The following is a description of a gene set: Genes predicted to be targets of miRBase v22 microRNA hsa-miR-2110 in miRDB v6.0 with MirTarget v4 prediction scores > 80 (high confidence targets). from publication Chen Y, Wang X (PMID 31504780) studied in species Homo sapiens Human Gene Set: MIR2110, and this is the list of marker genes: RNF169, SMAGP, ARFGEF3, IL6ST, PCM1, TBC1D8B, SGTB, GPR135, PRDM8 (NCBI Gene Id 56978), WASF2, WNT5A, XBP1, GBP3, RSAD2, ELK1, CALCA, ZFX, MMACHC, PTGR3, MCPH1, YY1AP1, ASPH, ASTN1, CCL8, CXCL11, OLIG1, HECTD3, ZMAT4, ENO2, UBE3C, SERINC1, UBR3, ITSN1 (NCBI Gene Id 6453), WBP1L, HSPE1-MOB4, ATP6V1G2, ZNF609, HNRNPA1, PTOV1, BCAM, USP12, TBR1, TPH1, PTER, NRAS, GDF11, CEP135, ZFP28, AGAP2, PI4KB, SPOCK3, CNIH3, THAP2, ENAM, DIRAS2, RARB, CD1E, SLC25A33, MBD2, TNRC6A, PRCC, G3BP1, FGFR1, VWC2 (von Willebrand factor C domain containing 2), RPN2, RAB11FIP2, ACSL1, IFNLR1, MAP2K1, SLC41A1, PSTPIP2, ELAVL3, PTPN14, MOB4, BNC2, ETV4, MAP1A, MOCS1, YTHDC1, ZDHHC15, ZBTB4 (zinc finger and BTB domain containing 4), PYGB, ZNF831, LUC7L3, MED9, SUSD2, ZHX3, KIAA0825 (NCBI Gene Id 401202), KIF21B, ITPRID1, C1QTNF3, GGPS1, SEMA5A, RPH3A, CYYR1, CD69, NRIP1, COPZ2, PTPN1, CSNK1A1, LUZP2, PLEKHH1, TAOK3, NADK2, PSKH1, SMIM19, UNC5B, IGF2BP3, ZBTB39, CUL3, CCDC82, UVSSA, ZNF620, NECTIN2, SIPA1L3, TMED4, SH3BP4, S1PR3, YES1, CAPN11, TRAM1, MR1, FCHSD1, SEMA4G, TMEM144, ATP2B2, SLC4A10, COPZ1, NECTIN1, APOL4, SLC38A7, PCYOX1, SARM1, PATL1, RASL11B, PLEKHS1, PIK3R3, BRAF, RNASEH2A, SYNCRIP, BTBD3, WNT8B, LOXHD1, LRRTM2, PABIR1, GRID2, BCAS3, AGPAT4, SPRR4, CYREN, JOSD1, SLC38A1, CYP4A22, NMT1, ZDHHC8, TMEM182, SLC7A14, ZBTB44, LRRC75A, ZMYM4, SMS, FOXM1, ZNF516, GRIK1, ELOVL4, KSR2, G3BP2, PRKACA, INO80D, NAALADL2, RNF180, PBX2, FBXO41